The following is a description of a gene set: species: Mus musculus Estrogen-dependent gene expression Mouse Gene Set: REACTOME_ESTROGEN_DEPENDENT_GENE_EXPRESSION, and this is the list of marker genes: Med1, Erbb4, Nrip1, Gtf2f2, H2bc11, H3c7, H2bc9, Polr2i, Polr2h, Polr2k, H2bc14, H2bc22 (NCBI Gene Id 319188), Ep300, Esr1, H2bc24, H4c16, H3f3a, Polr2l, Ncoa1, Hsp90aa1 (heat shock protein 90, alpha (cytosolic), class A member 1), H4c11 (NCBI Gene Id 319159), Hsp90ab1, H3c1, Tle3, H4c3, Polr2d, Tbp, Gata3, H2bc8, H3c3 (NCBI Gene Id 319148), H3c13, H3c6, Polr2g, H2bc23, H4c4, Foxa1, Ccnt1, Kat5, Gtf2a1, Cbfb, Polr2c, Ddx5, H4c17, Prmt1, H4c9, H3c10, H2bc6, Gtf2a2, H4c1, Usf1 (NCBI Gene Id 269144), Polr2f, Gtf2f1, H2bc13, H4c8 (H4 clustered histone 8), Pgr, H4c12, H4c6, Polr2b, H4c2, H2bc21, H2bc7, H3f3b, H2aj, Carm1, Cdk9 (NCBI Gene Id 12574), H2bc15, Kat2b, H2bc12, H3c4, Greb1, H3c14, H2bc26, H2bc1, H3c8, Sp1, H3c2, H2bc4, Kdm1a, H4c18, Usf2, Ptges3, Polr2e, H3c11, Polr2a, Ncoa2, H2bc3, Fkbp4, Cited1, H3c15, H4c14